Given this list of marker genes Mboat2, Pla2g2a, Lpcat3, Lpcat4, Pla2g6, Pla2g1b, Pla2g12a, Pla2g5, Plb1, Pla2g2d, Pla2g4e, Pnpla8, Pla2g4c, Pla2g2f, Plbd1, Lpcat1, Tmem86b, Pla2g4d, Pla2g4a, Plaat3, Pla2g4b, Pla2g10, Pla2g2e (NCBI Gene Id 26970), Pla2r1, Pla2g3, Pla2g4f, Lpcat2, here is a description of the gene set: studied in species Mus musculus Mouse Gene Set: REACTOME_ACYL_CHAIN_REMODELLING_OF_PC Acyl chain remodelling of PC